The following is a description of a gene set: species: Homo sapiens Human Gene Set: chr1q44, and this is the list of marker genes: OR3D1P, RNU6-1283P, TGIF2P1, ENSG00000289566, OR2T29, KIF28P, C1orf202, OR2B11, RPL7AP82, SMYD3, DNAJC19P8, OR2L5, OR2L3, SMYD3-AS1, OR2X1P, ZNF692-DT, RPL23AP25, ENSG00000224521, OR2M4, AKT3, OR13G1, OR9H1P, ZNF672, CHCHD4P5, ZNF670-ZNF695, ENSG00000310332, RNA5SP82, MIR3916, OR2L2, RN7SKP55 (RN7SK pseudogene 55), OR2M2, CATSPERE, RPL35AP6, ZNF496, CLK3P2, OR14C36, RNU6-1205P, AKT3-IT1, OR14L1, OR2AJ1, OR2T11, RNU1-132P, OR2L6P (NCBI Gene Id 81465), OR2T34, OR6R1P, OR2G3, OR2T10, PGBD2, OR2C3, DESI2 (NCBI Gene Id 51029), RNU6-999P, OR2L8, OR2G6, ZNF669, OR2T3, SPMIP3 (NCBI Gene Id 200159), LINC02897, SH3BP5L (NCBI Gene Id 80851), OR6F1, OR2T33, OR2T8, OR2M3, OR2AK2, VN1R5, OR14I1, FABP7P1, GCSAML, OR2T2, OR2T27, AHCTF1, ZNF692, ENSG00000272195, OR2W5P, LYPD8, RNU6-1089P, SMYD3-IT1, OR14A2, OR2T32P, COX20, HNRNPU, VN1R17P, OR2T6, LINC02774, OR2T12, KIF26B, ZNF731P, OR2M5, OR2T35, OR2G2, CNST, FGFR3P6, EFCAB2, CYCSP5, RNU6-947P, OR2M7, OR14A16, MIR3124, DPY19L4P1, OR1C1, TFB2M, AHCYP8, LINC01341 (long intergenic non-protein coding RNA 1341), ADSS2, OR2L1P, LYPD9P, OR2T1, LINC01743, TRIM58, OR2T7, OR2L9P, ZBTB18 (NCBI Gene Id 10472), HSD17B7P1, OR2AS1P, ZNF695, SCCPDH, ENSG00000302155, OR2M1P, NLRP3, KIF26B-AS1, RN7SL148P, OR2AS2P, OR2T4, OR2L13, ZNF124, ZNF670, ZNF496-DT, OR14K1, OR11L1, OR2W3, OR2T5